Given this list of marker genes Pcdhb4, Fn1, Pcyt1a, Ccdc38, Agbl3 (ATP/GTP binding protein-like 3), Sh3d19, N4bp2l1, Herpud2, Scn9a, Cnot7, Setd2, Sec22b, Chic1, Hcn1, Pde7a, Meioc, Kif14, Fsd1l, Bank1, Acbd3, Mgat4c, Aph1b, Slco5a1 (solute carrier organic anion transporter family, member 5A1), Tnfrsf1a, Gucy1a2, Ppp1r21, Dbi, Skint3, Ripk1, Six6, Pex26, Pabpc4, Atp2a2, Ints12, Ascl2, Slitrk2, Or7d10, Pkdcc, Rnf138, Zbtb1, Trp53, Actr10, Rpgrip1l, Ugt8a, Ccdc80, Htr1f, Foxp2, Hao2, Aff4, Zxdc, Cdkn2d (cyclin dependent kinase inhibitor 2D), Cbx3, Tbpl1, Tmx3, Lactb2, Cetn1, Asrgl1, Kcnv1, Ereg, Nfix, here is a description of the gene set: Genes predicted to be targets of miRBase v22 microRNA mmu_miR_6390 in miRDB v6.0 with MirTarget v4 prediction scores > 80 (high confidence targets). Mouse Gene Set: MIR_6390 from publication Chen Y, Wang X (PMID 31504780) studied in species Mus musculus